The following is a description of a gene set: Any process that activates or increases the frequency, rate or extent of extrinsic apoptotic signaling pathway via death domain receptors. Human Gene Set: GOBP_POSITIVE_REGULATION_OF_EXTRINSIC_APOPTOTIC_SIGNALING_PATHWAY_VIA_DEATH_DOMAIN_RECEPTORS studied in species Homo sapiens, and this is the list of marker genes: PEA15, ATF3, STK4, ZSWIM2, PMAIP1, MAL, STK3, FAF1, THBS1, SFRP1, BMPR1B, SKIL